Given this list of marker genes DIP2B (disco interacting protein 2 homolog B), SIRT1, KAT5, KLF15, CEP295, FAM161A, XBP1, DIP2A, MAGEA2, MAGEA2B, BMAL1, here is a description of the gene set: Human Gene Set: GOBP_REGULATION_OF_PROTEIN_ACETYLATION studied in species Homo sapiens Any process that modulates the frequency, rate or extent of protein acetylation.